The following is a description of a gene set: species: Mus musculus The intramolecular conversion of uridine to pseudouridine within an RNA molecule. Mouse Gene Set: GOBP_PSEUDOURIDINE_SYNTHESIS, and this is the list of marker genes: Trub2, Pusl1, Pus10, Pus7, Rpusd2, Rpusd1, Tsr3 (NCBI Gene Id 78765), Pus1, Pus7l, Nop10, Rpusd3, Naf1, Nhp2 (NCBI Gene Id 68237), Trub1, Gar1, Rpusd4, Pus3, Dkc1